Given this list of marker genes Arid1a, Smarce1 (SWI/SNF related, matrix associated, actin dependent regulator of chromatin, subfamily e, member 1), Actb, Smarca4, Smarcc2, Smarcd2, Actl6b, Smarca2, Smarcb1, here is a description of the gene set: Mouse Gene Set: GOCC_BBAF_COMPLEX species: Mus musculus A brain-specific SWI/SNF-type complex that contains eight or nine proteins, including both conserved (core) and nonconserved components; contains the ATPase product of either the SMARCA4/BAF190A/BRG1 gene, the mammalian ortholog of the yeast SNF2 gene, or the SMARCA2/BAF190B/BRM gene, the mammalian ortholog of the Drosophila brm (brahma) gene, or an ortholog of either of these genes. Compared to the neuron-specific nBAF complex  it does not contain DPF1, DPF3 or SMARCC1 or their orthologs. May contain PB1/BAF180.